Given this list of marker genes PLAU, PPP1R15A, ITGA2, IGFBP1, DCN, CDKN1A, ECM2, HYOU1 (hypoxia up-regulated 1), ENPP2, EGFR, FN1, SEL1L, DENND2B, JUNB, VEGFA, GADD45A, CCNG2, RHOQ, MMP16, SERPINE1, here is a description of the gene set: Human Gene Set: ZHU_SKIL_TARGETS_UP from publication Zhu Q, Krakowski AR, Dunham EE, Wang L, Bandyopadhyay A, Berdeaux R, Martin GS, Sun L, Luo K (PMID 17074815) SnoN is an important negative regulator of transforming growth factor beta signaling through its ability to interact with and repress the activity of Smad proteins. It was originally identified as an oncoprotein based on its ability to induce anchorage-independent growth in chicken embryo fibroblasts. However, the roles of SnoN in mammalian epithelial carcinogenesis have not been well defined. Here we show for the first time that SnoN plays an important but complex role in human cancer. SnoN expression is highly elevated in many human cancer cell lines, and this high level of SnoN promotes mitogenic transformation of breast and lung cancer cell lines in vitro and tumor growth in vivo, consistent with its proposed pro-oncogenic role. However, this high level of SnoN expression also inhibits epithelial-to-mesenchymal transdifferentiation. Breast and lung cancer cells expressing the shRNA for SnoN exhibited an increase in cell motility, actin stress fiber formation, metalloprotease activity, and extracellular matrix production as well as a reduction in adherens junction proteins. Supporting this observation, in an in vivo breast cancer metastasis model, reducing SnoN expression was found to moderately enhance metastasis of human breast cancer cells to bone and lung. Thus, SnoN plays both pro-tumorigenic and antitumorigenic roles at different stages of mammalian malignant progression. The growth-promoting activity of SnoN appears to require its ability to bind to and repress the Smad proteins, while the antitumorigenic activity can be mediated by both Smad-dependent and Smad-independent pathways and requires the activity of small GTPase RhoA. Our study has established the importance of SnoN in mammalian epithelial carcinogenesis and revealed a novel aspect of SnoN function in malignant progression. Genes up-regulated in A549 cells (lung adenocarcinoma) upon SKIL knockdown by RNAi. species: Homo sapiens